Given this list of marker genes Slc7a6, Slc6a15, Slc25a44, Slc7a7, Slc7a5, Slc43a1, Llgl2, Slc38a9, Slc6a17, Slc7a8, Slc43a2, Slc3a2, here is a description of the gene set: The directed movement of branched-chain amino acids into, out of or within a cell, or between cells, by means of some agent such as a transporter or pore. Branched-chain amino acids are amino acids with a branched carbon skeleton without rings. studied in species Mus musculus Mouse Gene Set: GOBP_BRANCHED_CHAIN_AMINO_ACID_TRANSPORT